The following is a description of a gene set: Neighborhood of TNFRSF25 tumor necrosis factor receptor superfamily, member 25 in the MORF expression compendium Human Gene Set: MORF_TNFRSF25 Neighborhood of TNFRSF25 studied in species Homo sapiens, and this is the list of marker genes: PCGF1, ESR1, SOCS6, MYH2, CRHR1, SDC3, ITIH4, ADCYAP1, CD6, MC2R, TACC2, DDX11, F7, TGOLN2, SLC17A7, AMFR, SLC4A3, MOK, CYP11A1, IKBKE, TBX19, HMHB1, BNIP1, KLHL18, LINC00837, KANK2, ARSL, SLC6A9, PCBP3 (poly(rC) binding protein 3), ABO, GREM1, SLC46A3, TBC1D22A, FRYL, NEURL1, RASSF1, LBP, NOS2, SLC30A1 (solute carrier family 30 member 1), GRIK5, MPZL2, DEPDC5, GPR19, KRT86, ATP10B, AANAT, SLC22A24, MT4, POU6F1, ADAMTSL2, UGT2B15, HOXD4, JRK, KYAT1, TBX1, CTRL, ZKSCAN3, SULT4A1, IPCEF1, GRK4, FAT2, BMP10, NRTN, FUT6, BAHD1, MLN, CPZ, CEP135, DPT, HCRT (hypocretin neuropeptide precursor), CLPX, ARHGEF12, TMEM11, CYP2E1, ZNF500, DKK4, HABP4, SLC2A1, LSM12, BCL2, GPR15 (NCBI Gene Id 2838), CBARP, ATP6V0A2, NTPCR, ARL3, MAGEA9, AMMECR1 (NCBI Gene Id 9949), JAK3, GGT5, MPP2, SIX3, SLC12A4, PSG1, VKORC1, RUNX1, FSHB (NCBI Gene Id 2488), SPTB, SYNJ2 (synaptojanin 2), SCAPER, GNPAT, PLXNA3, CNKSR1, PRELID3A (NCBI Gene Id 10650), NGFR, SRPK3, PAX8, JAG1, PML, GLE1, CRYAA, GJB5, HTR1B, NXPE3, FOSL1, BARX2, TSPYL1, LINC00928, HTR4, PSD, PTPRS, CLOCK, TLN2, ARFGEF2, DRC3, ELAVL2, SEZ6L, ADRA1B, PIGR, BRD1, HNF1A, KRT1 (keratin 1), TENM4, CCKAR, ZNF592, AKAP3 (NCBI Gene Id 10566), PARVB, DGCR5, MYOZ3 (myozenin 3), SLC24A1, CYP2D6, SLC13A2, MSX1, SLC30A3, CYP2A6, RFC5, LTBP4, TNP1, PIGB, NFIC, ADCY3, PAX7, EIF5B, ETV3, PTH1R, ATP2B2, FDXR, ATRX (ATRX chromatin remodeler), ECE2, ABCB9, EXTL3, P2RY10, GSTM5, PAXIP1, DAPK2, SLC22A6, HTR7, TAF12, AQP5, MYC, WT1, IVL, TUBGCP4, COX6A2, KAZN, MYT1, MUSK, RBBP8, CALCOCO1 (calcium binding and coiled-coil domain 1), HAUS5, ZNF157 (NCBI Gene Id 7712), CD3E, PPIL2, PLEKHB1, NF1, PIAS2, KAT8, RALYL, NFRKB, KRT33B, FLT1, LDLRAD4, CRCP, MYO9B (myosin IXB), TRIM66, NFX1, TMEM94, MSL3, ZBTB40, ZNF330, GPATCH8, KRT33A (keratin 33A), RIMS2, POU6F2, GRIP2, AQP7, MDM2, ZNF710, ENTREP1, ARNT, RPS6KB2, ELL2, TBXT, ATP8A2, ABCA1, CDK5R1, AFF2, PRSS16, SLC18A1, EFNA2, MMACHC, SNRNP27, LPGAT1, SYT5 (NCBI Gene Id 6861), SRSF8, IMPA1, PIK3CB, CAMK2G, RPH3A, PRKACA, ITPKB, ITPR2 (NCBI Gene Id 3709), IL13, TM4SF5, FNTB, TBX5, UBE4B, TNFRSF25, IRF2, DNAJC16, CD8B, LTK, STK17A, LMO1, WDR62, DOK1, CYP19A1, CNTN2, PAX9, POLR2K, NCKIPSD, COLQ, MFN1, RHBDL1, SLC5A2, C1orf216, EML3, HSPB2, THRA, MC5R, PHF10, BTD, SLC16A5, PVR, SPEF1, CMA1, SSTR5